The following is a description of a gene set: species: Mus musculus Mouse Gene Set: GOBP_B_CELL_SELECTION The process dependent upon B cell antigen receptor signaling in response to self or foreign antigen through which B cells are selected for survival., and this is the list of marker genes: Bak1, Traf3ip2, Bax, Ighm, Btk